Given this list of marker genes FZD3, POU4F2, NRP1, CTNNB1, UNC5C, INSM1, NRP2, SEMA3A, TUBB3, SIX4, SEMA3F, PHOX2B, RGS4, SIX1, TULP3, ASCL1, here is a description of the gene set: The process whose specific outcome is the progression of a ganglion over time, from its formation to the mature structure. Human Gene Set: GOBP_GANGLION_DEVELOPMENT species: Homo sapiens